Given this list of marker genes NFATC2, YWHAB, MIR646HG, LKAAEAR1, PTPN1, PRELID3B, GID8, SYCP2, SLC17A9, C20orf204, ZNF217, DNAJC5, SLCO4A1, RNF114, KCNQ2, CTSZ, PMEPA1, MC3R, ATP5F1E (NCBI Gene Id 514), CEBPB, DOK5, UCKL1, GATA5, DIDO1, PARD6B, HELZ2, SALL4, PTK6, ZFP64, ZMYND8, ZNF512B, PEDS1, SS18L1, SDC4, FNDC11, UBE2V1, RBBP8NL, SOX18, NTSR1, PEDS1-UBE2V1, BCAS1, PREX1, TCFL5, NELFCD, TOMM34 (translocase of outer mitochondrial membrane 34), TUBB1, LAMA5, ARFGAP1, COL20A1, PPDPF, PI3 (NCBI Gene Id 5266), NPBWR2, FAM209B, KCNG1, RTF2, KCNS1, STX16, OSBPL2, HRH3, CDH4, ZBP1, MOCS3, VAPB, FAM210B, NPEPL1, RBM38 (NCBI Gene Id 55544), OPRL1, RBPJL, CYP24A1, BIRC7, PCK1, SRMS, STMN3, ZNF831, ADRM1, SAMD10, COL9A3, FAM209A, RTEL1, TP53TG5, BHLHE23, TFAP2C, CIMIP1, SLPI, CRMA, ARFGEF2, GMEB2, TNFRSF6B, SLC2A4RG, STK4, LIME1, SNAI1, ZGPAT, DPM1, BCAS4, PCMTD2, AURKA, PSMA7, CASS4, GNAS, MTG2, ATP9A, FAM217B, YTHDF1, APCDD1L, MIR1-1HG, BMP7, RIPOR3, NCOA3, OGFR, ARFRP1, SEMG1, CTCFL, TSHZ2, CBLN4, SEMG2, TCEA2 (transcription elongation factor A2), SPATA2, EEF1A2, EDN3, ABHD16B, MATN4, PFDN4, CABLES2, PRPF6, PPP1R3D, TAF4, RAE1, RAB22A, RGS19, SYS1, ZBTB46, MRGBP, MYT1, SULF2, WFDC12, PHACTR3, TPD52L2, WFDC5, NKAIN4, CDH26, ADNP, CSTF1 (cleavage stimulation factor subunit 1), RPS21, SLC9A8, CHRNA4, HMGB1P1, LSM14B, SPO11, here is a description of the gene set: from publication Nikolsky Y, Sviridov E, Yao J, Dosymbekov D, Ustyansky V, Kaznacheev V, Dezso Z, Mulvey L, Macconaill LE, Winckler W, Serebryiskaya T, Nikolskaya T, Polyak K (PMID 19010930) Human Gene Set: NIKOLSKY_BREAST_CANCER_20Q12_Q13_AMPLICON A single cancer cell contains large numbers of genetic alterations that in combination create the malignant phenotype. However, whether amplified and mutated genes form functional and physical interaction networks that could explain the selection for cells with combined alterations is unknown. To investigate this issue, we characterized copy number alterations in 191 breast tumors using dense single nucleotide polymorphism arrays and identified genes with copy number gain organized into 30 amplicons. Amplicons were distributed unequally throughout the genome. Each amplicon had distinct enrichment pattern in pathways, networks, and molecular functions, but genes within individual amplicons did not form coherent functional units. Genes in amplicons included all major tumorigenic pathways and were highly enriched in breast cancer-causative genes. In contrast, genes with somatic mutations in breast cancer were distributed randomly over the genome, did not represent a functionally cohesive gene set, and were relatively less enriched in breast cancer marker genes. Mutated and gained genes did not show statistically significant overlap but were highly synergistic in populating key tumorigenic pathways including transforming growth factor beta, WNT, fibroblast growth factor, and PIP3 signaling. In general, mutated genes were more frequently upstream of gained genes in transcription regulation signaling than vice versa, suggesting that mutated genes are mainly regulators, whereas gained genes are mostly regulated. ESR1 was the major transcription factor regulating amplified but not mutated genes. Our results support the hypothesis that multiple genetic events, including copy number gains and somatic mutations, are necessary for establishing the malignant cell phenotype. species: Homo sapiens Genes within amplicon 20q12-q13 identified in a copy number alterations study of 191 breast tumor samples.